Given this list of marker genes MESP1, VEGFA, MIR1-1, SRF, GPER1, NOTCH1, MIR145, HEY2, GATA6, MYOCD, here is a description of the gene set: Human Gene Set: GOBP_CARDIAC_VASCULAR_SMOOTH_MUSCLE_CELL_DIFFERENTIATION The process in which a relatively unspecialized cell acquires specialized features of a cardiac vascular smooth muscle cell. A cardiac vascular smooth muscle cell covers the heart vasculature and lacks transverse striations in its constituent fibers. species: Homo sapiens